Given this list of marker genes PITHD1, GARIN3, GARIN4, DKKL1, B4GALT1, SMCP, TNP2, PPP3R2, ACR, HEXB, HYAL3, here is a description of the gene set: Human Gene Set: GOBP_PENETRATION_OF_ZONA_PELLUCIDA The infiltration by sperm of the zona pellucida to reach the oocyte. The process involves digestive enzymes from a modified lysosome called the acrosome, situated at the head of the sperm. studied in species Homo sapiens